Given this list of marker genes ASCL1, HLTF, DRAP1, RFXAP, TRIM28, MED15, GTF2A2, CLOCK, MAX, MED26, TAF6L, GTF2A1L, POU2AF1, MAFK, RUNX3, ATF6, PASD1, NFATC2, NKX2-5, GTF2H4, SUPT3H, THRB, ATXN7L3, SMAD5, ERCC2 (NCBI Gene Id 7269), TFDP1, MED6, GTF2H2C, ATF4, BATF, HYAL2, TCF4, HAND1, KAT2A, MED1, NEUROD1, MAFF, CREM, TAF11L7, THRA, CDK7, TAF11L3, BATF2, GTF2E1, WWOX (NCBI Gene Id 9621), CBX3 (chromobox 3, NCBI Gene Id 82756), ADNP, ENY2, NFYB, LEF1, E2F8, STAT3, HIF1A, NFIL3, HMGA1, TAF1, NR5A1, GTF2A1, CREB1, E2F1, E2F2, CEBPG, GTF2F1, MAF, TADA3, FOSL2, NR1H4, MED11, TAF10, TAF11L13, TAF8, ERCC3, TEAD2, TCF7, HIPK2, TLE3, BACH1, TAF4, HLF, MNAT1, IRF9, NFE2, MED20, MXD3, PPARG, TAF11L6, ATF1, MYB, MMS19, XBP1, YAP1, BCL9L, TAF11, NFYC, MED29, STAT1, SFPQ, NCOA2, CEBPB, CRX (NCBI Gene Id 1406), NONO, MED4, RXRA, MED7, BACH2, TAF2, MED31 (NCBI Gene Id 51003), CBFB, NPAS2, GATA4, GTF2H2, ATF5, ATF3, BATF3, MED8, TAF1L, DBP, ING2, RB1, TAF9B, GTF2H5, NFE2L3, MED14, PAAF1, TCEA1 (NCBI Gene Id 7865), ANXA2, ATF6B, TAF11L11, FOSL1, TAF9, VDR, STAT5A, MED22, ASCL4, TAF11L2, MYF5, POU4F1, CTNNB1, GTF2B, GTF2H3, MED18, SMAD3, GTF2E2 (NCBI Gene Id 2961), TAF11L8, TFDP2, MED27, TAF13, ASCL2, TAF6, TBP, CEBPE, TCF7L2, TAF11L14, MYF6, MXI1, NR5A2, ASCL5, RFXANK, TAF4B, NCOA1, E2F5, POU2F1, TCF7L1, NFE2L2, HOXB9, GEMIN5, MED16 (mediator complex subunit 16), TAF11L12, S100A10, CCNH, TCF15, BCL9, SMAD1, TLE4, CHD4, JUND, USP22, ASCL3, FOS, E2F7, LDB1, STAT5B, MAFG, CREBZF, FOXH1, BMAL1, DDIT3, DR1, TBPL1, E2F4, GTF2F2, TEAD1, PBX1, MED21, ATF2, TAF11L4, BMAL2, PYGO2, MED24, TCF3, CREB3, TAF7L, TLE1, RFX5, STAT2, SMAD6, SMAD2, SMAD4, MAFB, SMAD9, MED30, TAF3, TAF11L9, HNRNPAB, GTF2H2C_2, LMO4 (LIM domain only 4), TAF12, CEBPD, JUNB, ARNT, MYC, TCF12, SMAD7, CEBPZ, MED10, MED17, DEAF1, CEBPA, STAT4, MED25, NR1H3, MED9, TAF7, TAF11L10, E2F3, ATXN7, JUN, TAF5L, RXRG, MED28, GTF2H1, RUNX1, JDP2, RARA, NFYA, TRRAP, ATF7, STAT6, NR1H2, MED19, MED23, RXRB, HNRNPU, E2F6, TAF5, here is a description of the gene set: studied in species Homo sapiens A transcription factor complex that acts at a regulatory region of a gene transcribed by RNA polymerase II. Human Gene Set: GOCC_RNA_POLYMERASE_II_TRANSCRIPTION_REGULATOR_COMPLEX